The following is a description of a gene set: Gangrene A serious and potentially life-threatening condition that arises when a considerable mass of body tissue dies (necrosis). species: Homo sapiens Human Gene Set: HP_GANGRENE, and this is the list of marker genes: NUMA1, MEFV, TBL1XR1, AGXT, HLA-DPB1, CTLA4, PROS1, ABCA12, CD28, ZBTB16, ALOXE3 (arachidonate epidermal lipoxygenase 3), BCOR, SDR9C7, SULT2B1, PRTN3, NPM1, PRKAR1A, ASPRV1, IFNGR1, KLRC4, TNFRSF1B, HLA-DRB1, NIPAL4, UBAC2, C4A, IRF2BP2, IL12A, HLA-B, FIP1L1 (NCBI Gene Id 81608), LIPN, CAT (NCBI Gene Id 847), STAT4, IL12B, FAS, PROC, PTPN22, KIF11, HLA-DPA1, IL10, ABCC6, TLR4, P4HA2, CCR1, CYP4F22, IL12A-AS1, ERAP1, MLX, TGM1, PML, ALOX12B, RARA, STAT5B, IL23R, NABP1, STAT3, ENPP1